Given this list of marker genes NTHL1, SDHA, SDHC, BMPR1A, APC, LMNA, COL14A1, MLH1, KIT, WRN (WRN RecQ like helicase), PDGFRA, GREM1, SDHB, STK11, MSH2, SDHD, AAGAB, SMAD4, here is a description of the gene set: species: Homo sapiens Neoplasm of the small intestine Human Gene Set: HP_NEOPLASM_OF_THE_SMALL_INTESTINE The presence of a neoplasm of the small intestine.